The following is a description of a gene set: Human Gene Set: NAKAYA_PBMC_FLUARIX_FLUVIRIN_AGE_18_50YO_CORRELATED_WITH_HAI_28DY_RESPONSE_AT_3DY_POSITIVE species: Homo sapiens Here we have used a systems biology approach to study innate and adaptive responses to vaccination against influenza in humans during three consecutive influenza seasons. We studied healthy adults vaccinated with trivalent inactivated influenza vaccine (TIV) or live attenuated influenza vaccine (LAIV). TIV induced higher antibody titers and more plasmablasts than LAIV did. In subjects vaccinated with TIV, early molecular signatures correlated with and could be used to accurately predict later antibody titers in two independent trials. Notably, expression of the kinase CaMKIV at day 3 was inversely correlated with later antibody titers. Vaccination of CaMKIV-deficient mice with TIV induced enhanced antigen-specific antibody titers, which demonstrated an unappreciated role for CaMKIV in the regulation of antibody responses. Thus, systems approaches can be used to predict immunogenicity and provide new mechanistic insights about vaccines. from publication Nakaya HI, Wrammert J, Lee EK, Racioppi L, Marie-Kunze S, Haining WN, Means AR, Kasturi SP, Khan N, Li GM, McCausland M, Kanchan V, Kokko KE, Li S, Elbein R, Mehta AK, Aderem A, Subbarao K, Ahmed R, Pulendran B (PMID 21743478) Genes positively correlated with HAI response at 28d in peripheral blood mononuclear cell in adults (18-50) after exposure to Fluarix/Fluvirin, time point 3D. Comment: Supplementary Table 5: All genes whose expression (d3/d0 or d7/d0) correlates to the fold increase in HAI titers (d28/d0)., and this is the list of marker genes: TYMP, MS4A7, TPPP3, FPGT, WBP1L, IRAG1, MSRB2, SERPINB1, KIR3DL1, JAML, HMBS, DFFA, OSBPL11, NLRP12, ADCY7, RASSF2, HNRNPAB, GSN, ZNF143, ARPC1B (NCBI Gene Id 10095), ZMYM6, SULT1A4, REEP4, NADK, DHRS9, ACLY, NCF2, ZSWIM6, CHURC1, CPPED1, CNIH4 (NCBI Gene Id 29097), NUDT16, CLEC4E (NCBI Gene Id 26253), BRI3 (brain protein I3), SNX27, IL17RA, EFHD2, SIRPA, ABCA7, SKAP2, IFITM3, HYCC1, CAPZB, TCF7L2, IQGAP1, LST1, ATP6V0D1, ENTPD1, PRMT5, SLC27A3, PTPRJ, LILRB2, CR1, PYCARD, ZYX (NCBI Gene Id 7791), CLTA (clathrin light chain A), FGD4, VPS35, TNFSF12-TNFSF13, SUSD1, GCA, SYK, APTX, CALML4, IL10RB, CHST15, PIK3AP1, SIRPB2, SIGLEC10, TRPS1, KIAA0513, RAB8A, DENND10, MAP2K4, APEH, OGDH, EIF4E2, RTL8C, CSTB, PRELID1, JUP, GLRX, TRIM14, ZNF641, GRN, S100A11, GCNT1, STX3, HK1, PRDX3, ORAI3, VNN2, DGAT2, SULT1A3, AGTRAP (NCBI Gene Id 57085), NQO2, CSK, SERPINA1, MBOAT7, RAB7A, RCBTB2, NDUFB3, CASP1, NCF1C, CD300A, PANK2, LRP1, SLC38A10, KCNMB1, SIL1, MBOAT1, SREK1, PUDP, CAP1, ATP10D, WSB1, STX6, MIR21, PRKACA, CREB5, DUSP18, LYST, CTBP2, CLMN (NCBI Gene Id 79789), TMEFF2, APLP2, NPL, TNFAIP2 (TNF alpha induced protein 2), ITGAX, IFNAR1, SORT1, MAPKAPK3, GAA, PPARGC1A, SLC25A11, SIRPB1, PACSIN2 (NCBI Gene Id 150377), IFI30, IMPA2, KIAA0930, CORO1B, TBCE, KDELR2, TOR1A, UBR2, SLC11A1, RNF149, BEST1, DGLUCY, MOB3A, HDAC5, UBE3C, GNS, CD93 (NCBI Gene Id 54591), WDFY3, RAB10, POU2F2, PECAM1, APAF1, NAGA, FPR2, SH3BP2, SLX1A, ASGR2, CASP10, CCR5, RBM19, ATP6V0A1, UBASH3B, UEVLD, CIDEB, PPP1R18, SLC8A1, DAGLB, ARF3, SLX1B, VMP1, SMC1A, CFD (complement factor D), KIAA2013, RBP1, RIPOR2, IDH1, CX3CR1, RBM47, PLXNC1, UBA1, DPYSL2, PCGF6, GBA1, PRDX1, C9orf72, CCPG1, CD58, ARAP1, SPTSSA, ATP6V1A, SULT1A1, IFNGR2, NME6, PPP2CB, ANPEP (NCBI Gene Id 290), SYT11, RAB27A, LILRA2, LILRA1, RNF135, ORMDL2, ABHD2, MCCC2, PPP1R11, KCNJ15, TBXAS1, CYREN, TMEM208, PLPBP, WASHC5, CAPG, NAGK, LYL1, APOBR, PMVK, FNDC3B, CTSD, ATP6AP1, M6PR, JPT1, MGST2, STEAP4, DBT, TMEM179B, MNDA, ANXA2R-AS1, SLAMF7, ASH2L, CD53, DAPK1, USB1, OSTM1 (osteoclastogenesis associated transmembrane protein 1), MAP2K3, TFEB (NCBI Gene Id 7942), CYFIP1, KCNJ2, CAPNS1, CRLS1, UBTD2, MAPK1, TM9SF1, PPM1L, NOD2 (nucleotide binding oligomerization domain containing 2), DDB2, CD36, BTK, ACTR3, JAGN1, STYXL1, NAAA, DRAM1, DCAF7, DCUN1D1, ARSD (arylsulfatase D), TRIQK, FRAT2, NCF4, TUT7, MOSPD2, FGL2, SECTM1, DMXL2, ENTPD4, TMEM80, PSEN1, HS1BP3, LILRB3, RTN1, NOL12, NEK9, SNX1, CLDN6, SIGLEC7, MSRB1, TMEM107, GK, AQP9, VRK3, RIGI, OS9, CARD8 (NCBI Gene Id 22900), ABHD18 (abhydrolase domain containing 18), VIPAS39, TCIRG1, SIGLEC5, YWHAE, LAMP2, TNFRSF1A, TET2, AHCYL1, LAT2, HK3, FRAT1, LAIR1, RPS6KA1, SEC23B, POLR1D, ASRGL1, GAPT, SEC23IP, FKBP15, TNFSF13, RNF24, APBB1IP, SLC12A6, HDLBP, EEFSEC (eukaryotic elongation factor, selenocysteine-tRNA specific), DENR, CKLF, PTAFR, PEPD, SMCO4, LILRB1 (NCBI Gene Id 23445), COX15, SPTLC2, UBE2R2, FGD2, PRRG4, KIR3DL2, C1orf162, RNF31, GALNT7, STAM2, TMEM218, PRRC2A, LARP4B, HCK, PCID2, GCNT2, SLC22A15, KCNK6, P2RY13, ARHGAP9, GALNT2, GLT1D1, PTPN6, ERICH1, CORO1A, SASH1, AKR1A1, PRAM1, ATG7, THOC2, MSL1, PPCDC, AP3S2, GRAMD4, MOGS, PILRA, SLC6A6, HSPA6, RXRA, MEGF9, GPBAR1, AGO4, SGCD, PRKCD, TLR5, ST8SIA4, TPI1, LRRK2, CSF3R, RAB1B, TRIOBP, RAB4B, TIMP2, VPS26C, NCF1B, HYPK, APH1B, SERF2, ILK, PAK1, SELPLG, RRAGD, PPID, KDELR1 (NCBI Gene Id 10945), CSF1R, QPCT, FAM193A, SEMA4A, IRF2, CSF2RB (NCBI Gene Id 3564), UVSSA, LILRA6, FBXL5, SFT2D1, ADIPOR2, ATP6V1B2, MILR1, RGS14, RALBP1, ARAP3, CAMSAP1, KCNE3, VDR, NAIP, VAV1, TAF4, PHKA2, HAL, PRKAR1A, MGST3, PRCP, CD4, AGPS, MICU1, LILRA3, ADA2, PADI2 (peptidyl arginine deiminase 2), DAXX, NCF1, KIR2DL2, SIGLEC12, NICOL1, FAR2, IFITM2, COA3, MPEG1